Given this list of marker genes Skint1, Cyld, Stat6, Themis, Slamf6 (NCBI Gene Id 80894), Cd74, Mtor, Il23a (interleukin 23, alpha subunit p19), Itpkb, Ptprc, Tgfb1, Brd2, Irf4, Nfatc3, Il4, Ep300, Cd3g, Loxl3 (lysyl oxidase-like 3), Stat3, Cd1d1, Tox, Ptpn2, Tbx21, Braf, Cd3e, Foxn1, Opa1, H2-DMa, Zap70, Cd3d, Dock2, Bcl11b, Tnfsf18, Cd69, Ly9, Batf (basic leucine zipper transcription factor, ATF-like), Spn (NCBI Gene Id 20737), Ctsl, Foxp3, Shh, Bcl2, Il6ra, Srf, Otud5, Stk11 (serine/threonine kinase 11), Il6, Brd4, Lgals1, here is a description of the gene set: The process of sparing immature T cells which react with self-MHC protein complexes with low affinity levels from apoptotic death. studied in species Mus musculus Mouse Gene Set: GOBP_POSITIVE_T_CELL_SELECTION